The following is a description of a gene set: Enables the energy-independent facilitated diffusion of a monoatomic anion through a transmembrane aqueous pore or channel. species: Mus musculus Mouse Gene Set: GOMF_MONOATOMIC_ANION_CHANNEL_ACTIVITY, and this is the list of marker genes: Clcnka, Gabra3, Slc17a3, Slc1a4, Glra2, Clcnkb, Clcn6, Slc17a6, Gabrb3, Clca4a (chloride channel accessory 4A), Lrrc8d, Clca3b, Slc1a1, Ano8, Glrb, Gabra6 (NCBI Gene Id 14399), Vti1b, Ttyh2, Slc26a7, Gabrb1, Gabra5, Apol9b, Clcn4, Apol11b, Vdac1, Clic3, Gabrd, Clcn2, Gabrb2, Ano6, Lrrc8a, Stx8, Apol10b, Ano1, Mcoln1, Lrrc8c, Best2, Apol11a, Ano10, Nmur2, Gabra2, Stx7, Clca2, Gabrr2, Cftr, Best3, Vdac2, Apol8, Clcn5, P2rx5, Ttyh1, Gabrg3, Slc26a11, Nherf1, Ano7, Slc17a7, Apol9a, Clca3a1, Slc1a7, Slc26a6 (solute carrier family 26, member 6), Slc17a8, Aqp6, Clcn3, Gabrp, Clca1, Glra3, Clca3a2, Gabrr1, Vdac3, Gabrg2, Apol10a, Clic1, Oca2, Ano9, Trpv1 (NCBI Gene Id 22366), Lrrc8b, Clca4b, Glra1, Shoc2, Mfsd8, Gabra1, Clic4, Chrna7, Gabra4, Pacc1, Stx1a, Lrrc8e, Gpr89, Best1, Clic6, Glra4, Ano4 (NCBI Gene Id 320091), Mcoln3, Clcc1, Ano2, Clcn1 (chloride channel, voltage-sensitive 1), Gabre, Slc26a9, Panx1, Tmc4, Gabrq, Slc26a8, Chrm5, Ano3, Cldn4, Cldn17, Gabrg1, Vamp8, Gabrr3, Bsnd, Clic5, Ttyh3, Ano5